Given this list of marker genes CA12, SCNN1B, ATIC, SCNN1A, MAGED2, CRELD1, IL36RN, IRF4, FOCAD, NFKB2, HSD3B2, ARNT2, EIF2AK3, SLC5A1, CLCNKB, SETD2, GCSH, SLC26A3, LYST, PAX2, BSND, POR, PKHD1, CYP11B2, RRAGD, AVPR2, MRAP, TDP2, TXNRD2, DSG1, OCRL, CA5A, AP1S3, SCN4A, PBX1, TICAM1, SAMD9, SCNN1G, SARS2 (NCBI Gene Id 59279), NDUFB8, SYK, TBX19, PPOX, ALAD, NUP214, PRF1, CPOX, ELP1, TSFM, HMBS, TRAF3, ALG12, NR0B1, TLR3, CYP11A1, GEMIN4, SLC9A3 (solute carrier family 9 member A3), TBK1, NNT, NR3C2, AQP2, ALG8, STAR, FGFR1, PLVAP, MC2R, UNC93B1, DZIP1L, CLCNKA, CTNS, here is a description of the gene set: An abnormal concentration of sodium. Abnormal blood sodium concentration Human Gene Set: HP_ABNORMAL_BLOOD_SODIUM_CONCENTRATION studied in species Homo sapiens